Given this list of marker genes AGBL5, RBP3, CLN3, LRP5, ALDH3A2, DCT, RDH5, SLC38A8, KLHL7, MTSS2, SAG, NEK2, SLC6A6, PAK2, LIG3, PDE6C, NDP, SYCE1 (NCBI Gene Id 93426), MERTK, PDE6H, GDF3, EPG5, CFH, IFT74, PRPF31, TULP1, PRPF6, SOX10, TOPORS, EDNRB, TYR, OFD1 (NCBI Gene Id 8481), VPS13B, AHR, HPS4, PRPF8, IKBKG, RNF113A, CCNQ, NRL, ANO10, NOD2, ZNF408, AGXT, SLC45A2, PAX2, HMCN1, ATF6, LYST, DRAM2, CC2D2A, SH3BP2, APC, FBLN1, MPLKIP, RHO, TMCO1, GUCA1B, ZNF513, CFAP418, NR2E3, IFT140, HLA-A, RPGRIP1, CLDN19, ZFYVE26, HGSNAT, AHI1, HTRA1, MPDZ, RPE65, TTC8, UNC119, MAPKAPK3, RD3, CLEC3B, TARS1, GPR143, CFI, RS1, ITPR1, BLOC1S3, SCAPER, WDR19, APOE, SEMA4A, FBLN5, CTNNA1, HARS1, DHX38, PRPF3, AHDC1, CRB1, CERKL, BBS2, DPYD, RDH12, IDH3B, MMACHC, MAF (MAF bZIP transcription factor), CACNA1F, PROM1, EDN3, SPATA7, PRCD, BBS5, SLC7A14, VHL, FOXC1, ASAH1, GTF2H5, COG1 (NCBI Gene Id 9382), ARL6, EFEMP1, RLBP1, HPS5, CDHR1, EYS, CEP78, USH2A, BBS1, CNGB1, WT1, ABCC6, CA4, GRK1, GUCA1A, TUB, CP, SLC24A5, C9, CTNNB1, ADAR, PRPS1, CNNM4, PAX6, BLOC1S5, CLCN2, KIZ, POMGNT1, TSPAN12, RAB28, CHM, PPT1, RAX2, TENM3, YARS1, AARS1, TREX1, ABCA4, PEX1, NF2, GBA1, IFT88, PLK4, SPG11, CLRN1, CNGA1, COL18A1, RP1, ARHGEF18, HMX1, LRAT, AIPL1, MFSD8, FBN2, VWA8, ELOVL4, REEP6, IFT172, PRPH2, CHST6, RP2, HK1, ERCC2, MYO5A, TRIM44 (NCBI Gene Id 54765), PCYT1A, MC1R, ATOH7, ARL3, GTF2E2, BEST1, MFRP, MAK, MITF, PDE6G, FZD4, DPM1, CRLS1, NEU1, CDH3 (NCBI Gene Id 1001), KIAA1549, FAM161A (FAM161 centrosomal protein A), CYP4V2, XYLT2, IDS, PRPF4, FSCN2, RP1L1, RBP4, DHDDS, SLC25A19, CFHR3, XYLT1, HPS6, ROM1, SIX6, RGR, SLC24A1, FZD5, CFHR1, ATXN7, CARS1, TLCD3B, AP3D1, OCA2, TRNT1, OAT, CNGA3, OPN1LW, KCNV2, GDF6, TRAF3IP1, IMPDH1, SMPD1 (NCBI Gene Id 6609), CRX, PITPNM3, GNAT2, PCARE, PDE6B, GUCY2D, LAMB2, IMPG1, ERCC3, EBP, SAMD7, LCA5, PRR12, OPN1MW, CCND1, PDE6A, TNFRSF11B, UGP2, RPGR, IDH3A, ENPP1, TIMP3, CST3, PIGA, C1QTNF5, CNGB3, RP9, LZTFL1, NLRP3, IMPG2, ARL2BP, SNRNP200, NMNAT1, here is a description of the gene set: A structural abnormality of the macula lutea, which is an oval-shaped highly pigmented yellow spot near the center of the retina. Abnormal macular morphology species: Homo sapiens Human Gene Set: HP_ABNORMAL_MACULAR_MORPHOLOGY